The following is a description of a gene set: Human Gene Set: GOMF_OXIDOREDUCTASE_ACTIVITY_ACTING_ON_THE_CH_CH_GROUP_OF_DONORS_WITH_A_FLAVIN_AS_ACCEPTOR Catalysis of an oxidation-reduction (redox) reaction in which a CH-CH group acts as a hydrogen or electron donor and reduces a flavin. studied in species Homo sapiens, and this is the list of marker genes: ACADL (NCBI Gene Id 33), TECR, ACAD10, ACAD9, ACAD8, GCDH, ACADVL, IVD, ACADSB, ACADM, ACAD11, ACADS